The following is a description of a gene set: Human Gene Set: GOBP_MEMBRANE_TUBULATION studied in species Homo sapiens A membrane organization process resulting in the formation of a tubular projection. This may face inwardly (as in tubular membrane invaginations) or outwardly (as in endosomal tubules)., and this is the list of marker genes: CIBAR1 (CBY1 interacting BAR domain containing 1), OPA1, DNM2, TMCC1, MICALL2, CORO1C